The following is a description of a gene set: from publication Cui A, Huang T, Li S, Ma A, Pérez JL, Sander C, Keskin DB, Wu CJ, Fraenkel E, Hacohen N (PMID 38057668) studied in species Mus musculus Cytokines mediate cell-cell communication in the immune system and represent important therapeutic targets. A myriad of studies have highlighted their central role in immune function, yet we lack a global view of the cellular responses of each immune cell type to each cytokine. To address this gap, the authors created the Immune Dictionary, a compendium of single-cell transcriptomic profiles of more than 17 immune cell types in response to each of 86 cytokines (>1,400 cytokine-cell type combinations) in mouse lymph nodes in vivo. A cytokine-centric view of the dictionary revealed that most cytokines induce highly cell-type-specific responses. For example, the inflammatory cytokine interleukin-1β induces distinct gene programmes in almost every cell type. A cell-type-centric view of the dictionary identified more than 66 cytokine-driven cellular polarization states across immune cell types, including previously uncharacterized states such as an interleukin-18-induced polyfunctional natural killer cell state. Genes positively differentially expressed in cell type: pDC (plasmacytoid dendritic cell) upon treatment with cytokine: IL-2 in mouse lymph nodes in vivo. Mouse Gene Set: CUI_PDC_IL2_RESPONSE_UP, and this is the list of marker genes: Csf2rb, Bcl11a, Bcl3, Rap1a, Csf2rb2, Ccnd3, Ldlr, Emp3, Pcbp1, Hnrnpa2b1, Actg1 (NCBI Gene Id 230535), Abhd17b, Pou2f2, Tubb4b, Lifr, Cbfa2t3, Eif4g2, Irf1, Iqgap1, Cd82, Cox5a, Hnrnpab, Sqle, Eloc, Chd4, Eif3a, Stat3, Gpx4, Eif4a1, Trip12, Pmepa1, Slc30a4, Sub1, Ptprc, Gna13, Kmt2d, Socs3, Idi1 (isopentenyl-diphosphate delta isomerase), Trp53i11 (transformation related protein 53 inducible protein 11), Macir, Pfn1, Ptpn1, Hmgcr, Calm1, Eif1, Sbno2, Kdr, Arpc5, Ikzf2, Slc6a6, Sdc4, Hmgcs1, Runx1, Cd7, Iigp1, Litaf, Gls, Gnb1, Pim1, Il7r, Bzw1, Atp2b4